Given this list of marker genes Gnai3, Gng13, Plcb1, Gng10, Cdk5, Grk2, Gnai2, Pomc, Gnb2, Prkaca, Pde1a, Gnb3, Gna14, Prkar1b, Gng11, Gng2, Ppp2r5d, Ppp1ca, Prkcd, Pde1b, Camkk2, Adcy1, Adcy8, Prkar1a, Gng4, Adcy3, Mapk1, Camkk1, Adcy4, Gng5, Pde1c, Pde4d, Gnat3, Gng3, Ppp1r1b, Adcy7, Pde4c, Calm2, Pla2g4a, Ppp2r1a, Gnai1 (NCBI Gene Id 14677), Calm1, Gng7, Gnaq, Gng12, Plcb3, Prkcg, Adcy9, Gnal (guanine nucleotide binding protein, alpha stimulating, olfactory type), Adcy6, Calm3 (calmodulin 3), Gngt2 (guanine nucleotide binding protein (G protein), gamma transducing activity polypeptide 2), Ppp2cb, Adcy2, Gnb1, Gna11, Gnb5, Gng8, Plcb4, Ppp2r1b, Pde4a, Gnb4, Gngt1, Plcb2, Prkacb, Gna15, Ppp2ca, Adcy5, Oprm1, Pdyn, Pde4b, here is a description of the gene set: species: Mus musculus Mouse Gene Set: REACTOME_OPIOID_SIGNALLING Opioid Signalling